Given this list of marker genes UBB, UBA52, FGF16, GRB2 (NCBI Gene Id 80715), FGF17, CBL, KLB, UBC, FGF19, SRC, FRS2, MAPK1, MKNK1, FGF2, FGF6, PPP2CB, SPRY2, FGF18, FGF1, FGF20, FGF8, FGFR4, PTPN11, PPP2CA, FGF9, FGF23, RPS27A, FGF4, BRAF, MAPK3, PPP2R1A, here is a description of the gene set: Negative regulation of FGFR4 signaling species: Homo sapiens Human Gene Set: REACTOME_NEGATIVE_REGULATION_OF_FGFR4_SIGNALING